Given this list of marker genes Tafa4, Tgfb1, Fpr2, Ncf4, Sod1, Acp5, Prg3, Pon3, Sh3pxd2a, Crp (C-reactive protein, pentraxin-related), Noxo1, Prkcd, Ncf1, Cybb, Sod2, Egfr, Itgb2, App, Rac2, Mapt, Gstp1, Agt, Duox2, Abcc1, Cxcl1, Ncf2, Cd177, Itgam, Agtr1a, Itgb2l (NCBI Gene Id 75978), Tyrobp, Syk, Hvcn1, F2rl1, Cyba, Gnai2, Noxa1, Elavl1, Il18, Duox1, Gnai3, Akt1, Sh3pxd2b, Nox1, Edn1, Clec7a, Nox3 (NCBI Gene Id 224480), Nox4, here is a description of the gene set: species: Mus musculus Mouse Gene Set: GOBP_SUPEROXIDE_ANION_GENERATION The enzymatic generation of superoxide, the superoxide anion O2- (superoxide free radical), or any compound containing this species, by a cell in response to environmental stress, thereby mediating the activation of various stress-inducible signaling pathways.